Given this list of marker genes Serpine1, Ctsh, Rgn, Hmgcs2, Cfh, Apoc2l, Mmp8, Mst1, Crip2, Proc, Capn5, Plg, Dusp6, Rac1, Vwf, Cpb2, Mmp10, Msrb2, Pef1, C8a, Lamp2, Lta4h, Sparc, C8b (NCBI Gene Id 73971), Apoc3, F10, Pdgfb, Thbs1, C1qa, Anxa1, Ctso, C3, Csrp1, P2ry1, Ctsb, Rabif, C2, Apoa1, Gsn, Dpp4, Cpq, Klf7, Plau, Cpn1, Masp2, Hpn, Casp9, Sirt2, Mmp14, Ang, Acox2, Gng12, Klkb1, Pecam1, Clu, Proz, Mmp3, Bmp1, Gnb2, C1s1, S100a1, Plek, Iscu, Fga, Olr1, Ctsk, Fgg, Hnf4a, Maff, Htra1, Fn1, Plat (NCBI Gene Id 51950), Dct, Adam9 (ADAM metallopeptidase domain 9), Furin, F8, Serping1, F12, Arf4, Tmprss6 (NCBI Gene Id 71753), S100a13, Cd9, Prep, Comp, Gp1ba, Mmp11, C9, Hrg, Itih1, Tfpi2, Fbn1, Serpinc1, Klk8, Mmp9, Sh2b2, F13b, Cfd (NCBI Gene Id 11537), Itga2, Gda, F2rl2, Capn2, Lgmn, Usp11, F3, Timp3, Mep1a, Dusp14, F11, F2, Lrp1, Gp9, Mmp2, F9 (NCBI Gene Id 14071), Pf4, Wdr1, Prss23, Rapgef3, Pros1, C8g, Thbd, Ctse, Apoc1, Mmp7, A2m, Ctsl, Timp1, Serpinb2, Mbl2, Mmp15, Cfi, Cfb, Fyn, Itgb3, Trf, here is a description of the gene set: species: Mus musculus Mouse genes annotated to HALLMARK_COAGULATION based on orthology mappings provided by the Alliance Genome Consortium from publication Howe DG, Blake JA, Bradford YM, Bult CJ, Calvi BR, Engel SR, Kadin JA, Kaufman TC, Kishore R, Laulederkind SJF, Lewis SE, Moxon SAT, Richardson JE, Smith C (PMID 30224793) Mouse Gene Set: HALLMARK_COAGULATION